Given this list of marker genes SLC30A9, GAA, DSG2, DMD, FHL1, here is a description of the gene set: Human Gene Set: HP_INCREASED_CIRCULATING_CREATINE_KINASE_MB_ISOFORM An increased concentration of the MB isoform of creatine kinase in the blood circulation. species: Homo sapiens Increased circulating creatine kinase MB isoform